Given this list of marker genes Tnpo2, Hnrnph1, Pknox2, Cfap300, Frat1, Cfap20dc, Ss18l1, Supt6, Mbtd1, here is a description of the gene set: Genes predicted to be targets of miRBase v22 microRNA mmu_miR_6970_3p in miRDB v6.0 with MirTarget v4 prediction scores > 80 (high confidence targets). from publication Chen Y, Wang X (PMID 31504780) Mouse Gene Set: MIR_6970_3P studied in species Mus musculus